Given this list of marker genes DNAH10, GNAS, SOX10, XPC, ARX, KDM5C, SLC39A4, NDNF, RPL10, NR5A1, FBXO43, FANCL (FA complementation group L), IFT27, PRKAR1A, BBS4, ERCC3, BBS2, SIM1, RAD51C, SHOC1, FANCC, ALMS1, SNRPN, USP9Y, FMR1, MEIOB, GLI2, SOX9, POLA1, NSMF, IL17RD, NDN, CEP112, GLI3, CTDP1, HSD3B2, CUL7, PDHA2, CYP17A1, TAF4B, ERCC5, ERCC2 (NCBI Gene Id 7269), DHX37, PHF8, FSHB, TTC8, CUL4B, RSPO1, THOC2, MKKS, GNRHR, H4C5, FGFR1, CHRM3, PROKR2, FAM111A, PHGDH, CFTR, PQBP1, BRIP1 (BRCA1 interacting helicase 1), CHD8, CEP19, DAZ1, BBS9, FANCG, FANCD2, GBA2, IL1RAPL1, TSHB, CDKN1C, TERB1, SLC29A3, HSPG2, MAD2L2, FANCA, CCDC34, OTX2, CCDC28B, BRCA1, CYP19A1, FANCB, FGF17, MAP3K7, KISS1, ZFPM2, NPHP1, GDF6, HDAC8, DAZ2, STAG3, BBS5, CEP290 (centrosomal protein 290), RNF113A, MSH5, LEPR, BBS7, IFT74, SLX4, LHX4 (NCBI Gene Id 89884), TAC3, AKT1, SOX3, KCNJ6, SCAPER, LZTFL1, ZMYND15, UPF3B, B4GAT1, CHD7, SPAG17, DAZ4, UBE2T, SAMD9, TACR3, XRCC2, CCDC141 (coiled-coil domain containing 141), PMM2, MECP2, SEMA3A, RLIM, MAP3K1, FANCF (NCBI Gene Id 2188), FLRT3, TOGARAM1, PNLDC1, TRIM32, RFWD3, ZPR1, OCA2, RAD51 (NCBI Gene Id 5888), TCTN3, NHLH2, TEX11 (testis expressed 11), BRCC3 (NCBI Gene Id 79184), TERB2, CYP11A1, FGF8, CYP11B1, RPL10L, FANCI, LEP, SYCP3, POU1F1, TYMS, OGT (NCBI Gene Id 8473), WWOX, XPA, DNAJC19, MAGEL2, KISS1R (KISS1 receptor), SRA1, DDB2, SCLT1, LHCGR, MOV10L1, CYB5A, ARL6, CATIP, MBTPS2 (NCBI Gene Id 51360), FOXA2, BBS1, SEMA3E, PALB2, PROK2, WT1, CT55, MCM8, SYCE1, WDPCP, DCAF17, TBC1D20, NF1, DKC1, NANOS1, WDR11, DDX3Y, DAZ3, WRN, SRY, BBS10, SDCCAG8, FANCE, SOHLH1, ZDHHC9, ANOS1, SPRY4, RAB18, KLHL10, BRCA2, DCC, SATB2, RBMY1A1, BBIP1, TSPY1, MED12, DNHD1, PROP1, VAMP7, RBMX, TEX15, TEX14, PDE11A, RNF212, FBN1, NAA10, CLIC2, MKS1, CFAP418, FEZF1, NR0B1, GNRH1, DMXL2, AXL, PHF6, IFT172, AGA, ERCC4, HS6ST1, DUSP6, GATA4, TDRD9, ATRX, HESX1, BBS12, FANCM, here is a description of the gene set: Human Gene Set: HP_ABNORMALITY_OF_THE_TESTIS_SIZE Abnormality of the testis size An anomaly of the size of the testicle (the male gonad). studied in species Homo sapiens